The following is a description of a gene set: Human Gene Set: GOBP_HEXOSE_PHOSPHATE_TRANSPORT studied in species Homo sapiens The directed movement of hexose phosphate into, out of or within a cell, or between cells, by means of some agent such as a transporter or pore., and this is the list of marker genes: SLC37A2, SLC37A1 (NCBI Gene Id 54020), SLC17A3, G6PC1, SLC37A4, SLC37A3, G6PC3